The following is a description of a gene set: species: Mus musculus Any process that results in a change in state or activity of a cell or an organism (in terms of movement, secretion, enzyme production, gene expression, etc.) as a result of a pain stimulus. Pain stimuli cause activation of nociceptors, peripheral receptors for pain, include receptors which are sensitive to painful mechanical stimuli, extreme heat or cold, and chemical stimuli. Mouse Gene Set: GOBP_RESPONSE_TO_PAIN, and this is the list of marker genes: Col6a1, Crh, Gja4, Grik1, Ednrb, Scn11a, Trpv1, P2rx4, Grin2b, Kcnip3, Scn10a, Osm, Runx1, Lpar5, Capn2, Thbs1, P2rx3, Nmur2, Slco1b2, P2rx2, Ucn (urocortin), Trpa1, Gria1, Comt, Crhr1, Cacna1b, Slc6a2, Akt1, Pirt, Htr7, Prkcg, Reln, Ntrk1, Git2 (GIT ArfGAP 2), Adam11, Mtor, Ret, Cacna1e, Calca, Aqp9, Thbs4, Scn9a, Tac1, Atat1, Cntnap2, Cacna1a (NCBI Gene Id 12286), Dbh, Tacr1, Scn3a, Gch1, Tspo (translocator protein), Vwa1